The following is a description of a gene set: Any process that stops, prevents, or reduces the frequency, rate or extent of the multiplication or reproduction of chondrocytes by cell division, resulting in the expansion of their population. A chondrocyte is a polymorphic cell that forms cartilage. species: Homo sapiens Human Gene Set: GOBP_NEGATIVE_REGULATION_OF_CHONDROCYTE_PROLIFERATION, and this is the list of marker genes: CCN3, BMPR1B, MIR21, BMPR2, SMAD7